Given this list of marker genes MAPKAP1, PPP2R5E, SRC, THEM4, PPP2R5A, PIK3CB, PPP2R1B, PIK3CA (phosphatidylinositol-4,5-bisphosphate 3-kinase catalytic subunit alpha), PIK3R5, PPP2R1A (protein phosphatase 2 scaffold subunit Aalpha), FYN, PIK3R6, VAV1, MTOR, RICTOR, LYN, PPP2R5C, MAP3K8, PIK3R1, RAC1, AKT1, CTLA4, PRR5, YES1, PIK3CG (phosphatidylinositol-4,5-bisphosphate 3-kinase catalytic subunit gamma), TRIB3, PDPK1, MAP3K14, PPP2R5D (protein phosphatase 2 regulatory subunit B'delta), PPP2R5B, PAK3, PIK3CD, AKT3 (AKT serine/threonine kinase 3), PIK3R3 (NCBI Gene Id 8503), LCK, GRAP2, PIK3R2, CD80 (NCBI Gene Id 941), CD86, PAK1 (p21 (RAC1) activated kinase 1), PAK2, PPP2CB, MLST8, AKT2, GRB2, PPP2CA, CDC42, CD28 (NCBI Gene Id 940), here is a description of the gene set: Human Gene Set: REACTOME_CO_STIMULATION_BY_CD28 Co-stimulation by CD28 studied in species Homo sapiens